Given this list of marker genes C4BPA, UGT2A1, REG3A, UGT2A2, SLC22A5, C4BPB, GPX1, here is a description of the gene set: Human Gene Set: GOBP_RESPONSE_TO_SYMBIONT species: Homo sapiens Any process that results in a change in state or activity of a cell or an organism (in terms of movement, secretion, enzyme production, gene expression, etc.) as a result of a stimulus from a symbiont, an organism living with an organism of a different species in close physical association. The symbiont is defined as the smaller of the organisms involved in a symbiotic interaction.